Given this list of marker genes CCNQ, POGZ, INF2, KMT2D, LMBR1, BRD4, NOG, SVBP, TBX3, RFC2, COL1A1, MFN2, KCNJ5, SUZ12, FIBP, KRAS, SCARF2, MEF2C, PSAT1, IQSEC2, BUD23, PIGG, IFT80, CTU2, PRKCZ, INTS1, WDPCP, ROBO1, NXN, PLEC, MYH3, H4C9, ERI1, GLI1, EVC2, ALOX12B, NR4A2, MAN2C1, HEPACAM, OFD1, OTUD5, POLR3GL, GRIP1, RNU4ATAC, MED25, EBF3, COL6A2, OTUD6B, SYT1, SETD5, ITGB4, ALDH6A1, LIMK1, CANT1, PIGN, NEK9, MYL11, ZMPSTE24, EXTL3, UFD1, DYNC2I2, SLCO2A1, PITX1, ATRIP, ZNF469 (NCBI Gene Id 84627), CNOT2, SLC35C1, DEAF1, CKAP2L, CSNK2A1, NPR3, PLK4, NECTIN1, SMAD4, ASPH, IFT74, SETBP1, GATAD2B, ESCO2, EZH2, FANCE, ERF, CWC27, RERE, BMPR1A, TRIM8, HSD17B4, EHMT1, FLII, NEFL, NBAS, ALOXE3, HYLS1 (NCBI Gene Id 50957), NAA10, C12orf57, MIA3, CCDC47, NEK1, TRPM3, NKX3-2, EP300, TWIST1, RETREG1, GNPNAT1, CHST11, FRA10AC1, HS2ST1, PEX7, MIR17HG, DNA2, SUFU, RYR3, VPS37D, KCNA1, HOXD13, SPTAN1, PCGF2, IGF1R, SLC29A3, PIGL, ALG12, UBE4B, KAT6A, RMRP, FHL1, CASK, PRKG2, MKKS, RAD51C, TCTN3, IMPDH2, PIK3CA, KCTD1, KATNIP, PPP1R21, COL12A1, PRDM16, WASF1, FBN2, RIPK4, PRKAR1A, MEIS2, RFWD3, NEDD4L, DHCR7, BMPER, CPLX1, PRKACA, FGFR1, LIG4, GJA8, EIF4A3, MYH8, TXNL4A, DMXL2, GABRD, LTBP4, EVC, VPS13B, DNAJC30, PIGP, DDX6, GPC3, SLX4, TMEM231, SMC3, NBN, SATB2, DYNC2H1, HRAS, B3GAT3, CEP104, DLL4, SH3TC2, PORCN, IQCE, METTL27, JARID2, DPM1, CERT1, PSMB8, NSDHL, TCF20, ACAN, COL6A3, BMP4, NOTCH1, FANCC (NCBI Gene Id 2176), FRAS1, CTDP1 (CTD phosphatase subunit 1), ASXL1, GATA4, ERMARD, COL2A1, CREBBP, EN1, IRF6, HARS1, PHIP, NCF1 (neutrophil cytosolic factor 1), SUMF1, SEC24C, NOD2, TBC1D2B, SYT2, GNE (NCBI Gene Id 81868), GTF2IRD1, TTI2, IL11RA, NRAS, TAF4, SALL1, NONO, B3GALT6, PIGF, MPV17, AHI1, MAP3K20, TBX5, TTC21B, ZMIZ1, CPT1C, MAPRE2, LMNA, TGDS, PDE4D, RNF6, PRG4, FDFT1, SMS, MAN1B1, IFT122, SLC25A22, PIEZO2, KAT8, IFT172, FIG4, CTCF, B4GALT7, SF3B4, PDPN, GBA1, HSPB8, ATR, TGFB3, PDE6D (NCBI Gene Id 5147), SACS, SCN4A, TMEM107, HBA1, IFT43, WDR19 (NCBI Gene Id 80203), GLI3, SCAF4, ARL6IP6, CD96, HBA2, KIF7, COL1A2, TBR1, KAT6B, TBX15, TMEM237, CEP55, TMEM260, IL7R, C2CD3, RHOA, IFT140, ATP6V1B2, CTBP1, KIAA0586, YY1, SRY, DLEC1, GTF2I, HDAC8, ERLIN2, LZTFL1, HNRNPK (heterogeneous nuclear ribonucleoprotein K), MAD1L1, ARL3, BMS1, RAB3GAP1 (NCBI Gene Id 338380), LRSAM1, ADAMTS2, DSP, KMT2B, CENPE, GNAO1 (G protein subunit alpha o1), RALA (RAS like proto-oncogene A), LIFR, BMP2, GCH1 (NCBI Gene Id 93984), B3GLCT, PIGQ, TRAIP, SNRPN, PRKD1, ARHGAP31, KCNN3, SCN9A, CPT2, THOC6, TP63, DYNC2I1, CEP41, PALB2, PYCR2, NRCAM, INPP5E, SMARCAD1, WNK1, ADCY6, RAG1, FAM149B1, ZNF699, LARS1 (leucyl-tRNA synthetase 1), ABCA12, EFNB1, LUZP1, PMP2, ASAH1, ZNF407, NECTIN4 (nectin cell adhesion molecule 4), ODC1, FANCG, MAD2L2, MMP23B, GDF5, GALNT2, COG8, ARX, EIF4H, GBF1, ATP6V1E1, PRX, ALMS1, RAI1, MEGF8, VCP, POLR3A, VAC14, INTS8, ZNF668, XYLT2, SLC35A3, BSCL2, CNTNAP1, USP9X, SHOX, LETM1, GNAS, ROR2, SIK1, MYOD1, RAB7A, CC2D2A, JMJD1C, FREM2, SALL4, GHR, BMPR1B, TRPV4, SMARCD2, RAG2, ARL6, BRCA1, ACVR1, TBX22, MYRF, FLNA, GJA5, FBLN1 (fibulin 1), ATN1, RAB11B, EIF2AK3, NT5C2, GNAI1, PHYH, CHD7, RTL1, SMARCE1, PIGV (phosphatidylinositol glycan anchor biosynthesis class V), ASCC3, DYNLT2B, BLTP1, IL2RG, PIBF1, BBS12, EGR2, FBXW11, PAPPA2, BCOR, HDAC4, FAT4, ARID1A (NCBI Gene Id 8289, AT-rich interaction domain 1A), ITPR3, HIRA, SVIL, RAD51, PUM1, RAB23, SMAD2, TGFBR2, WIPI2, NSUN2, AP1G1, REEP1, GATA6, FANCF, PLEKHG5, IFT27, ARID1B, UBAP2L, IFT52, HNRNPH1 (NCBI Gene Id 3187), KCNJ8, ZSWIM6, HERC2, TMEM138, PDZD8, PTEN, RAB34, TBL2, RPL10, BBS2, HNRNPR, ESAM, IPO8, CHSY1, DACT1, NOTCH2, PIGO (NCBI Gene Id 84720), KMT5B (NCBI Gene Id 54794), BCR, ITCH, CUL4B, NUP85, NSD2, TRIO, SC5D, ATL3, CCDC22, FANCA, DDX59, KMT2A, TOR1A, MRPS28, GARS1, SMARCA2, COL3A1, WBP4, SIAH1, BAZ1B, NIPBL, TBX4, ZNF423, CSPP1, MTM1, PDXK, COX4I1, PPP2R1A, B9D2, WWOX, FGF10, SOX5, FLNB, RAD21, CILK1, DCPS, SLC12A6, SLC32A1, TMEM67, DYNC2LI1, TBC1D24, ARCN1, TCTN2, CASZ1, STAG1 (NCBI Gene Id 10274), BPNT2, ARVCF, DCLRE1C, FANCI, FGF16, SLC26A2, CDK10, ZEB2, PIGH, SMOC1, H3-3A, KCNH1, AMER1, TXNDC15, TMEM270, ABCC9, TMEM218, SOD1, MYCN (NCBI Gene Id 53360), PNKP, ALDH1A2, BBS1, COL11A2, TPR, TOGARAM1, CAMTA1, PCNT, APC2, NFIX, XYLT1, GTF2IRD2, RTN2, KIF1A (kinesin family member 1A), CSGALNACT1, FGFR2, SLC12A2 (NCBI Gene Id 6558), NEUROD2, TOPORS, TRMT10A, SHANK3, TRIP12, MPZ, DLX5, SHH, ADA, TBCK, FKBP6, KIAA0753, CHP1, PHF6, EIF5A, PTRH2, FANCB, LRP4, NKX2-6, CIBAR1, TCF4, CDC45, USP7, RPGRIP1L, HOXA13, CPLANE1, DLK1, TCF12, PUF60, RBBP8, MED12, GNA11, SHMT2, SPEN, DDX11, PPP1R15B, FREM1, DNMT3A, GNB4, APC, LBR, ZNF141, CLCF1, DNM1L (dynamin 1 like), PCDHGC4, SOX9, TELO2, PIGY, CEP152, HSPB1, DYRK1A, FGFRL1, MEG3, TRMT5, CLIP2, CEP290, ERCC4, NSD1, TRAF7, FBXO11, TFAP2B, EBP, SLC6A9, DVL1, TRRAP, KCNAB2, GJA1, MAB21L2, MTX2, GPC4, SCN2A, TAF6, SMO, AARS1, MAX, DOCK6, XRCC2, WNT5A, BPTF, SATB1, GDAP1, FAM20C, DCAF8, RNU4-2, RREB1, IRX5, BBS7, SLC16A2, STX1A, PTH1R, PMP22, B9D1, SMC1A, CCDC28B, GP1BB (NCBI Gene Id 89199), RSPRY1, CHRNG, FGF9, NPHP3, GDF6, MORC2, NKX2-5, PYCR1, ADNP (activity dependent neuroprotector homeobox), BHLHA9, NPR2, ITPR1, BRCA2, CBY1, CRKL, AKT1, AEBP1, TBL1XR1, MCTP2, VRK1, GPX4, TCTN1, MECP2, CEP295, PRKACB, SCNM1, TPM2, SPART (spartin), ZFX, SPECC1L, ABL1, KIAA0825, CDKL5, CDC42, WLS, RPGRIP1, COX7B, SMARCA4, SBF2, ALG3, SIK3, RHBDF2, TMCO1, ARL13B, UBA2, FBN1, PLAA, COMT, NDRG1, IHH, KIF1B, NUP107, CDH3, MMP2, SCN1B, TMEM216, ZMYM2, FANCD2, PTHLH, HEATR3, WNT10B, UBE2T, RBPJ, IFT57, PRDM5, PHF8, MKS1, GRM7, TNNT3, TMEM94, ARMC9, CEP120, HEPHL1, HSPG2, PPP2R5D, FANCL, UBE2A, RAB3GAP2, ATP2B1, MAPK1, NELFA, MLXIPL, COL6A1, GRIN1, HPGD, MGP, SIGMAR1, PHGDH, TBX1, SKI, KDM5A, RFX7, ACTB, BBS9, EXT2, CHST3 (NCBI Gene Id 9469), FLI1, FANCM, CACNA1C, SLC39A8, KCNJ2, CHCHD10, COA7, FGFR3, WNT7A, PLAAT3 (NCBI Gene Id 11145), TWIST2, SIN3A, ERCC1, HUWE1, EOGT, ARSL, JUP, GMNN, GABRA3, BRIP1, ELN, TLL1, ATP9A, MBD5, here is a description of the gene set: Abnormal toe morphology Human Gene Set: HP_ABNORMAL_TOE_MORPHOLOGY species: Homo sapiens An anomaly of a toe.